The following is a description of a gene set: species: Mus musculus Binding to a protein-lipid complex, any macromolecular complex that contains both protein and lipid molecules. Mouse Gene Set: GOMF_PROTEIN_LIPID_COMPLEX_BINDING, and this is the list of marker genes: Ihh, Msr1, Crp, Pon1, Gpihbp1, Pcsk9, Apoa1, Scarb1, Apoa2, Apoe, Colec12, Stab2, Trem2, Stab1, Scarf1, Vldlr, Thbs1, Pltp, Lipc, Lsr, Samd1, Abca1, Mapt (NCBI Gene Id 17762), Cd36, Ldlr, Lpl, Lrp8, Sorl1, Cdh13, Hspd1